The following is a description of a gene set: Genes positively differentially expressed in cell type: ILC (innate lymphoid cell) upon treatment with cytokine: IL-12 in mouse lymph nodes in vivo. species: Mus musculus from publication Cui A, Huang T, Li S, Ma A, Pérez JL, Sander C, Keskin DB, Wu CJ, Fraenkel E, Hacohen N (PMID 38057668) Mouse Gene Set: CUI_ILC_IL12_RESPONSE_UP Cytokines mediate cell-cell communication in the immune system and represent important therapeutic targets. A myriad of studies have highlighted their central role in immune function, yet we lack a global view of the cellular responses of each immune cell type to each cytokine. To address this gap, the authors created the Immune Dictionary, a compendium of single-cell transcriptomic profiles of more than 17 immune cell types in response to each of 86 cytokines (>1,400 cytokine-cell type combinations) in mouse lymph nodes in vivo. A cytokine-centric view of the dictionary revealed that most cytokines induce highly cell-type-specific responses. For example, the inflammatory cytokine interleukin-1β induces distinct gene programmes in almost every cell type. A cell-type-centric view of the dictionary identified more than 66 cytokine-driven cellular polarization states across immune cell types, including previously uncharacterized states such as an interleukin-18-induced polyfunctional natural killer cell state., and this is the list of marker genes: Mrps36, Serpina3f, Stimate, Ifih1, Gatb, Mrpl3, Ppa1